Given this list of marker genes GJB4, TOMM40, GJB7, GJE1, VDAC3, GJA10, MPEG1, GJA9, GJA3, TOMM40L, GJD4, GJD2, PANX2, GJB1, VDAC2, GSDMB, GJC1, GJC3, GSDMD, GJB3, GJC2, GJD3, GJA1, GSDME, GSDMA, GJA8, BAK1, GJB2, PANX3, VDAC1, PRF1, PANX1, GJA4, GJB5, GJA5, GJB6, GSDMC, here is a description of the gene set: species: Homo sapiens Human Gene Set: GOMF_WIDE_PORE_CHANNEL_ACTIVITY Enables the energy-independent facilitated diffusion of propanediol through a large pore, un-gated channel. Examples include gap junctions, which transport substances from one cell to another; and porins which transport substances in and out of bacteria, mitochondria and chloroplasts.